The following is a description of a gene set: The process in which the anatomical structures of a metanephric nephron tubule are generated and organized. A metanephric nephron tubule is an epithelial tube that is part of the metanephric nephron, the functional part of the metanephros. studied in species Mus musculus Mouse Gene Set: GOBP_METANEPHRIC_NEPHRON_TUBULE_MORPHOGENESIS, and this is the list of marker genes: Pkd1, Lgr4, Sox9, Hes5, Pax8, Hes1, Sox8, Pax2